Given this list of marker genes PLXNC1 (NCBI Gene Id 121370), LY96, ARRB2, S100A4, C5AR1, MNDA (NCBI Gene Id 4332), TLR1, PILRA, RGS2, NCF2, APOBEC3A, LST1, LILRA2, HCK, P2RY13, MYO1F, UBE2D1, FPR1, AIF1, CLEC7A, CCR1, EVI2B, SECTM1, IGSF6, CSF3R, SPI1, DPEP2 (dipeptidase 2), TNFSF10, FCGR2A, SDCBP, here is a description of the gene set: Human Gene Set: GNF2_TNFSF10 Neighborhood of TNFSF10 species: Homo sapiens Neighborhood of TNFSF10 tumor necrosis factor (ligand) superfamily, member 10 in the GNF2 expression compendium